Given this list of marker genes Tk2 (NCBI Gene Id 57813), Dck, Tk1, Dguok, Adk, here is a description of the gene set: Catalysis of the reaction: ATP + 2'-deoxynucleoside = ADP + 2'-deoxynucleoside 5'-phosphate. Mouse Gene Set: GOMF_DEOXYNUCLEOSIDE_KINASE_ACTIVITY species: Mus musculus